Given this list of marker genes KCNK6, DRD3, UCN, NOS2, GJA5, KL, TNF, ADIPOQ, TAC1, MRGPRD, NOS3, GPR37L1, VEGFC, NOS1, ADRA1A, GLP1R (NCBI Gene Id 2740), DRD5, DRD2, ADRB2, PPARA, ABCC9, ADRB3, RNLS (renalase, FAD dependent amine oxidase), NTSR1, BBS4, GUCA2B, NPPB, ADM2, ADRB1, FFAR3, SCPEP1, BMPR2, ADORA1, APLN, NPPA, IER3, SNX5, AGTR2 (NCBI Gene Id 186), CALCA, MKKS, MAS1, OXT, SOD2, MIR17, ARHGAP42, ABAT, CRH, TAC4, NPY, PRCP, BDKRB1, here is a description of the gene set: Any process in which the force of blood traveling through the circulatory system is decreased. studied in species Homo sapiens Human Gene Set: GOBP_NEGATIVE_REGULATION_OF_BLOOD_PRESSURE